The following is a description of a gene set: species: Homo sapiens Enables the transfer of a solute or solutes from one side of a membrane to the other according to the reaction: bile acid(out) + Na+(out) = bile acid(in) + Na+(in). Human Gene Set: GOMF_BILE_ACID_SODIUM_SYMPORTER_ACTIVITY, and this is the list of marker genes: SLC10A6, SLC10A5, SLC10A1, SLC10A2, SLC10A4, SLC10A3 (solute carrier family 10 member 3)